The following is a description of a gene set: Genes up-regulated in dendritic cells: diphenyleneiodonium (DPI) versus DPI and 2,4-dinitrofluorobenzene (DNFB). species: Homo sapiens from publication Miyazawa M, Takashima A (PMID 22974541) Human Gene Set: GSE20727_ROS_INH_VS_ROS_INH_AND_DNFB_ALLERGEN_TREATED_DC_UP Identification of ROS induced genes on dendritic cells Dendritic cells were incubated for 15 min with or without a ROS inhibitor (DPI), washed extensively and incubated for 30 min with a chemical allergen (DNFB), hydrogen peroxide, and vehicle alone in HBSS containing DPI or vehicle. After washed extensively, the samples were post-incubated for 5.5 h with DNFB, hydrogen peroxide, or vehicle in complete culture medium containing DPI or vehicle., and this is the list of marker genes: NUP58, FCGR2A, IL7, YIPF1, RALGPS2, DENND2D, SPIN1, RIMKLB, GTF2F1, PLTP, ZNF410, MEA1, NAGS, SERTAD1, KREMEN1, CCDC167, TLR1, PROS1, CASP5, HIPK3, MIDN, ATP13A2, KIF3B, CYTH2, IL12RB2, CD53, MAFG, DRAM1, DNAJC25, NABP1, LILRA6 (NCBI Gene Id 79168), SLCO2B1, C1orf21, PRR5L, STOM, ARL13B, SLC16A10, GRB10, RHOC, SMIM12, GK3, COQ10B, PIK3AP1, GTF3C6, CDK9, SLC16A7, ADGRA2, CDKN1B, TRIB1, OLFML2B, TUBB2A, KCTD10, GYG1 (NCBI Gene Id 2992), ADM, VPS26A, HMGN5, HK3, DONSON, NAMPT, MAF, SERPINB9, FAM114A1, CLIC1, SH3PXD2B, HRH1, KRAS, CPEB4, CXCL13, GPR18, BASP1, RBM47, PNKD, TUBB4B, KIFBP, GNG2, LILRB2, TMC6, PSMD9, LILRB1, CD36, JAK3, MS4A4A, HEG1, HS3ST1 (heparan sulfate-glucosamine 3-sulfotransferase 1), DDAH2, CCDC47, PRDM2, FPR2, CARM1, LAMP1, HLX, PLEKHA3, METRNL, PUS3, MARCHF1, CARD6, MYO7A, CCDC9, CNEP1R1, RELT, DCHS1, XRN2, PLOD3, PFKFB3, MFAP3, SLC2A3, TUBA1C, PLGRKT, BTG2, SLAMF6, MIR3945HG, DCTN4, SOCS3, INTS12, UBE2F, TNIP3, ANKS1A, GNA15, H3-3B, DSE, JMJD6, CCDC32, HPGD, CD47, RHOB, SGCB, C2CD3, IL21R, TM2D2, ARG2, CHMP4A, TRPV2, BATF, RBMS1, AP2A2, FRMD4A, CC2D1B, MYO1G, GNA13, AGFG1, PIM1, SNX8, TRAPPC14, SAMD8, FAM89B, PDGFA, FLVCR2, MCOLN1 (NCBI Gene Id 57192), NELFE, STK35, FAM20A, SUSD1, SYNGR2, SHB, WDFY3, IL7R, PRR5, GAS6, PTPN2 (NCBI Gene Id 5771), DNAJA4, SLAMF1, VPS37A, LAMB3, STK19 (serine/threonine kinase 19), KATNA1, TIGAR, TLNRD1 (NCBI Gene Id 59274), CRK, ECT2, SGMS1, DLGAP1-AS1, ENSG00000291149, SLC2A8, NIPA1 (NIPA magnesium transporter 1), SMS, IRS1, ADAP2, RRAGC, MIR22HG, TWF1, LRCH1, SNX9, SNHG12, SLC8A1, PCED1B, BCAP29, BCL7B, NECTIN2, CLTA, ARHGAP12, GALNT10, ITGB5, ANKRD6, CREM, LAIR1, SNX24, JAZF1, JOSD2